The following is a description of a gene set: studied in species Homo sapiens Cell cycle regulators and carbohydrate transporters. Human Gene Set: MODULE_573, and this is the list of marker genes: RLBP1, CDKN1C, CDKN2A, ALOX5AP, UCP2, GMNN, VWF, TBRG4, CDKN1A, GADD45A, LCN2, SLC2A3, CDKN2C, SLC25A16, SLC2A5, TNC, PPBP, HSP90B1, MYC, CDKN3, SESN2, KAT2B, AKR1C2, UCP1, AMBP